The following is a description of a gene set: Human Gene Set: HP_PES_VALGUS An outward deviation of the foot at the talocalcaneal or subtalar joint. studied in species Homo sapiens Pes valgus, and this is the list of marker genes: PPP1R15B, SMOC1, GARS1, PIGG, MYMX, SCN4A, MAPK8IP3, TPM3, BSCL2 (BSCL2 lipid droplet biogenesis associated, seipin), RFT1, GDF5, MYPN, SCN1A, GABRA1, TRMT10A, EBF3, TRIP4, SMG9, WAC, SCN1B, COL9A3, CDC42BPB, LARGE1, REEP1, KDELR2, GABRG2, COL6A2 (collagen type VI alpha 2 chain), SCN9A, CACNA1C, CAPN1, SCN2A, COL6A3, MAP3K7, BAG3, SLC16A2 (solute carrier family 16 member 2), WDR19, RAI1, FLNA, SPRED2, SYT1, PCDH19 (protocadherin 19), COL6A1, LONP1, ANO1, COL12A1, MBD5 (NCBI Gene Id 55777), HK1, TPM2, PUF60, TCF4, TOR1A, GNB2, SH3TC2, FBN1, H4C5, HNRNPR